Given this list of marker genes GATA6, FURIN, TSKU, IL13, TYROBP, CD2AP, LILRB1, FN1, CD24, LAPTM4B (NCBI Gene Id 55353, lysosomal protein transmembrane 4 beta), FBLN1, here is a description of the gene set: Any process that stops, prevents, or reduces the frequency, rate, or extent of production of transforming growth factor-beta. Human Gene Set: GOBP_NEGATIVE_REGULATION_OF_TRANSFORMING_GROWTH_FACTOR_BETA_PRODUCTION species: Homo sapiens